Given this list of marker genes Epo, Cry1, Spidr, Usp14, Nfrkb, Txndc12, Micu1, Bag6, Usp1, Mapt, Supt20, Manf, Coro2b, Map4k4, Parp3, Rtn4rl1, Uimc1, Pnp, Smarca4, Mapkap1, Crebbp, Atf6, Thy1, Smarce1, Ino80, Ankrd1 (NCBI Gene Id 12907), Efhd1, Bcl2l1 (BCL2-like 1), Dnajb9, Nacc2, Igf1r, Mtch2 (NCBI Gene Id 80443, mitochondrial carrier 2), Mrgbp, Yeats4, Hgf, Agr2, Tada1, Pbk, Ndel1, Hdac6, Kat5, Nck1, Sf3b3, Cebpg, Taok2, Fbh1, Ep300 (NCBI Gene Id 328572), Ajuba, Hdgfl2, Sirt7, Znhit1, Snai1, Riox1 (NCBI Gene Id 71952), Ifi205, Park7, Bfar, Tlr4, Tldc2, Ell3, Trpm2, Pik3cb, Knl1, Ntrk3, Ogg1, Oprm1, Abl1, Ddah1, Prkn (parkin RBR E3 ubiquitin protein ligase), Mbtd1, Ifi204, Xrcc4, Shld3, Rnf168, Map2k2, Dpf3, Clu, Commd1, Tmem161a, Zfp365, Ddrgk1 (DDRGK domain containing 1), Hbb-bs, Pmaip1, Fmn2, Crhbp, Npm1, Tada3, Bcl7c, Polq, Rtca, Pot1b, Psmd10, Brd7, Hmgb1, Actr8, Ercc8, Alox5, Bak1, Smarcd3, Eno1, Pcbp4, Aunip, Il1b, Bok, Ing3, Cav1, Eno1b, Fut8, Parp1, Rpa2, Pbrm1, Omg, Xrcc1, Kat7, Morf4l1, Trrap, Dek, Bcl7b, Rnf8, Actr5, Eif2ak3, Foxm1, Tbc1d24, Inava, Dmap1, Pnkp, Spring1, Mapk1, D130043K22Rik, Brcc3, Eny2, Tmx1, Prrx1, Usp47, Oxr1, Hapstr1, Rnf185, Ddx5, Pttg1ip, Bad, Csnk2a1, Atad5, Lpcat3 (NCBI Gene Id 194356), Nck2, Tsc1, Taf10, Arl6ip5, Pigbos1, Helq, Senp3, Kcnk2, Adcy8, Cbx8, Stk24, Ccar2, Cgas, Spire1, Card9, Steap3, Map3k20, Zcwpw1, Tnr, Sgf29, Ccdc117, Smchd1, Chek1, Adam17, Ddx11, Sf3b5, Cers2, Selenos, Stk19, Pla2r1, Chordc1, Smarcd2, Svip, Skp2, Ppp4r3c1, Usp22, Mid1, Abcd1, Klhdc10, Rps3, Crhr2, Dhx9, Dyrk3, Nod2, Tti1, Cxcl12, Ino80c, Zmpste24, Fkbp1b, Ubxn1, Ubqln4, Kmt5b, Fas, Rad52, Spred2, Atr, Setmar, Akt1, Lrp1, Braf, Mdm2, Epha4, Smarcc2, Xbp1, App, Grem1, Apbb1, Tifab, Taf6l, Hic1, Ing4, Chchd2-ps, Nr1h3, Usp51, Bard1, Actl6b, Dusp10, Taf5, Arid1a, Sirt6, Actb, Letm1, Sema4c, Snai2, Chchd2, Ercc6, Slf1, Eya2, Cyren, Rfwd3, Rif1, Ager, Bcl2l12, Ptprs, Spire2, Sox4, Rnaseh2b, Ifi211, Tmed2, Smarcc1, Ep400, Sgta, Actl6a, Eya1, Trp53bp1, Trp53, Diaph1, Blm (NCBI Gene Id 12144), Cdkn2a, Nfe2l1, Nbr1, Brca2, Trim28, Trim32, Rad51, Twist1, Wrap53, Usp13, Wfs1, Kmt5c, Babam2, Ficd, Rock2, Prkcg, Ppp1r10, Nbn, Epc1, Etaa1 (NCBI Gene Id 68145), Wdr48, Paqr3, Grina, Grn, Eya3, Actr2, Taok3, Ogt, Diaph2, Taf9, Dpf1, Dnaja1, Pten, Bcl7a, Mrnip, Ppp4r3b, Eif2ak1, Eef1e1, Skil, Ruvbl1, Pdcd10, Cd36, Taf6, Ooep, Atad3a, Fgf10, C1qbp, Pcna, Opa1, Drd2, Parpbp, Otub1, Cops3, Prdx1 (NCBI Gene Id 18477), Tmem259, Pdx1, Abraxas1, Uchl5, Xylt1, Mgmt, Aifm2, Slc38a2, Stat3, Atxn7, Ier3, Flna, Meak7, Stk25, Ufl1, Shld2, Ikbkg, Tmem33 (NCBI Gene Id 78493), Muc1, Spred1, Fh1, Epc2, Rnf146, Herpud1 (NCBI Gene Id 64209), Brcc3dc, Dpf2, Taf12, Hspb1, Creb3l1, Yy1, Akt3, Dhfr, Zbtb7b, Mre11a, Rnft1, Babam1, Tigar, Meaf6, Rad51ap1, Rtn4, Hyou1, Bax, Setd7 (NCBI Gene Id 73251), Eif2ak2, Slc25a23, Drd1, Pot1a, Supt7l, Foxo1 (forkhead box O1), Rtn4r, Ncoa7, Slc25a14, Top2b, Pik3r1, Pdia6, Tex15, Creb3, Ppp4r3a, Terf2ip, Nod1, Atxn3, Hmga2, Bdkrb2, Peli1, Atxn7l3 (ataxin 7-like 3), Ripk2, Morf4l2, Dnmt3a, Insig2, Ptprf, Aqp11, Tmbim6, Usp15, Smarca2, Ercc1, Gch1, Timeless, Smarcd1, Pum2, Pnpla8, Rnf126 (NCBI Gene Id 70294), Plk1, Phf10, Brd8, Ruvbl2, Scarf1, Tpt1, Rnf183, Taf5l, Recql5, Qars1, Prmt1, Ubqln1, Hnrnpk, Fus, Suv39h1, Slf2, Nr1h2, Igfbp6, Brca1, Il1a, Ptpn2, Mapk8ip2, Helb, Taok1 (NCBI Gene Id 67240), Ino80b, Mbtps2 (membrane-bound transcription factor peptidase, site 2), Fem1b, Khdc3 (KH domain containing 3, subcortical maternal complex member), Ptn, Kdm4d, Ppia, Lrrk2, Fancb, Daxx, Ybx3, Chek2, Atm, Clec7a, Brd4, Amfr, Klf4, Ppp4r2, Cd44, Atrip, Slc7a11, Ercc4 (excision repair cross-complementing rodent repair deficiency, complementation group 4), Mapk3, Rnft2, Bid, Tgfb2, Nudt16l1, Rad9a, Crebrf, Ube2n, Hsf1, Prkdc, Syvn1, Dyrk1a, Ube2v2, Fbxo4, Scimp, Mmp14, Fcgr2b, Mcrs1, Eif2a, Radx, Map2k1, Cul4a, Reg3b, Gstp1, Npas2, Cntf, Serinc3, Fbln5, Nsd2, Mad2l2, Ino80d, Vhl, Spop, Ddias, Rtel1, Nfe2l2, Setd2, Shld1, Kat2a, Usp25, Hspa5, Nrg1, Smarcb1, Pias4, Abca7, Rpl26, Wdr76, Tfpt, Lrig2, Taf7, Smyd2, Eya4, Trp73 (transformation related protein 73), Kdm6a, Zfp385a, Scly (selenocysteine lyase), Rgma (NCBI Gene Id 244058), Ier5, Kdm1a, Rnf169, Ern1, Stub1, Inpp5f (NCBI Gene Id 79372), Cdk9, Rmi2, Plscr1, Vps72, Klhl15, Egfr, Hmgcr, Triap1, Fech, Usp19, Sirt1, Cdkn2d, Ptgs2, Erp29, Cln3, Arid2, Igtp, Was, Ackr3, Marchf7, Nupr1, Akt2, Sncg, Ppp4r3c2, Cops5, Met, Hdac10, Ubqln2, Nek1, Phf13, Kat2b, Pml, Cd74, Kremen1, Nol3, Atf6b, Pink1, Ppp4c, Bcap31, Tmem67, Mif, Parg, Kmt5a, Taf2 (TATA-box binding protein associated factor 2), Neo1, Axin2, Insig1, Ubxn2a, Fam168a, Fads2, Ptpn1, Fignl1, Yju2, here is a description of the gene set: Any process that modulates the frequency, rate or extent of a cellular response to stress. Cellular response to stress is a change in state or activity of a cell (in terms of movement, secretion, enzyme production, gene expression, etc.) as a result of a stimulus indicating the organism is under stress. The stress is usually, but not necessarily, exogenous (e.g. temperature, humidity, ionizing radiation). Mouse Gene Set: GOBP_REGULATION_OF_CELLULAR_RESPONSE_TO_STRESS species: Mus musculus